Given this list of marker genes PYDC1, IL6, MIR21, IL1RN, SIGIRR, TAX1BP1, ZNF675, IL1R2, MIR27A, OTUD4, here is a description of the gene set: Any process that stops, prevents or reduces the frequency, rate or extent of interleukin-1-mediated signaling pathway. Human Gene Set: GOBP_NEGATIVE_REGULATION_OF_INTERLEUKIN_1_MEDIATED_SIGNALING_PATHWAY species: Homo sapiens